The following is a description of a gene set: A reduced circulating concentration of adiponectin, a 30-kDa complement C1-related protein that is the most abundant secreted protein expressed in adipose tissue. Human Gene Set: HP_DECREASED_ADIPONECTIN_LEVEL Decreased adiponectin level studied in species Homo sapiens, and this is the list of marker genes: LIPE, AKT2, LMNA, CIDEC, PCYT1A